The following is a description of a gene set: species: Homo sapiens Human Gene Set: WP_METABOLISM_OF_ALPHALINOLENIC_ACID Metabolism of alpha-linolenic acid, and this is the list of marker genes: ALOX5, ALOX15, FADS2, ALOX12, PTGS2, FADS1